The following is a description of a gene set: Mouse Gene Set: chr7D1 species: Mus musculus, and this is the list of marker genes: Gm44758 (NCBI Gene Id 115486533), Gm7693, Fam174b, Gm26176 (predicted gene, 26176), Mir7234, Slco3a1, Agbl1, Gm6567, C130083A15Rik, A730056A06Rik (RIKEN cDNA A730056A06 gene), Gm4971, Gm7726, Chd2, Gm10619, Gm30459, Gm5597, St8sia2, Gm36696, 2310001K20Rik, Idi1-ps4, Gm10161 (NCBI Gene Id 635260), 4930533N22Rik, AU020206, Mctp2, Sv2b, 4933435G04Rik, Kansl2-ps, Gm21269, 1700011C11Rik, Rgma, Gm20083, Rpl17-ps10, A830073O21Rik, Chaserr, 1500012K07Rik, 4930429H19Rik, Gm5335, Gm44689, Akap13, Gm30075, Klhl25, Gm7675, Gm36633 (predicted gene, 36633, NCBI Gene Id 102640608), 0610006L08Rik, Gm17988, 4930441H08Rik (NCBI Gene Id 78156)